The following is a description of a gene set: Genes positively differentially expressed in cell type: NK cell upon treatment with cytokine: IL-3 in mouse lymph nodes in vivo. Mouse Gene Set: CUI_NK_CELL_IL3_RESPONSE_UP Cytokines mediate cell-cell communication in the immune system and represent important therapeutic targets. A myriad of studies have highlighted their central role in immune function, yet we lack a global view of the cellular responses of each immune cell type to each cytokine. To address this gap, the authors created the Immune Dictionary, a compendium of single-cell transcriptomic profiles of more than 17 immune cell types in response to each of 86 cytokines (>1,400 cytokine-cell type combinations) in mouse lymph nodes in vivo. A cytokine-centric view of the dictionary revealed that most cytokines induce highly cell-type-specific responses. For example, the inflammatory cytokine interleukin-1β induces distinct gene programmes in almost every cell type. A cell-type-centric view of the dictionary identified more than 66 cytokine-driven cellular polarization states across immune cell types, including previously uncharacterized states such as an interleukin-18-induced polyfunctional natural killer cell state. from publication Cui A, Huang T, Li S, Ma A, Pérez JL, Sander C, Keskin DB, Wu CJ, Fraenkel E, Hacohen N (PMID 38057668) studied in species Mus musculus, and this is the list of marker genes: Laptm5, Tubb4b, Gzmb, Gnb2 (NCBI Gene Id 14693), Gzma (granzyme A), Agpat3, Fxyd5